The following is a description of a gene set: A deviation from the normal count of dense granules per thrombocyte. Abnormal number of dense granules studied in species Homo sapiens Human Gene Set: HP_ABNORMAL_NUMBER_OF_DENSE_GRANULES, and this is the list of marker genes: HPS4 (NCBI Gene Id 89781), HPS5, AP3B1, HPS6, HPS3, IKZF5, BLOC1S5